The following is a description of a gene set: studied in species Homo sapiens Human Gene Set: WP_TNFALPHA_SIGNALING TNF-alpha signaling, and this is the list of marker genes: JUN, DIABLO, MAP3K1, TRADD, CASP7, CUL1, HSP90AA1, BIRC3, BIRC2, KSR2, NSMAF, IKBKB, MAP2K3, AKT1, BTRC, KRAS, PPP2CA, TNF, TRAF2, CASP8, MAPK3, NRAS, CASP9, REL, PYGL, TRAF1, BCL2L1, CDC37, BAD, CHUK, PTPRCAP, TNFRSF1A (NCBI Gene Id 8077), NOX1, NFKB2, NFKBIB, TRAP1, CCL2 (NCBI Gene Id 6347), CASP3, PSMD2, RAF1, IL6 (interleukin 6), RAC1, SELE, OTUD7B, NOXO1, MAPK1, BAX, FADD, NFKBIA, MADD, NFKBIE, MAP3K3, MAP2K6, MAP3K8, TNFAIP3, FBXW11, PLK1, TANK, PRKCZ, RIPK1, TBK1, IKBKG, MAPK9, MAPK8, TNFRSF1B, MAP3K5, HRAS, GRB2, MAP3K7, CSNK2A1, TAB1, MAP4K2, CYBA, KSR1, GLUL, CREBBP, RIPK3, RFFL, APAF1, MAP2K4, SKP1, MAP2K7 (mitogen-activated protein kinase kinase 7), NFKB1, TXN, SOS1, SMPD2, RFK (NCBI Gene Id 55312), TAB2, BID, MAP3K14, CFLAR, TAB3